Given this list of marker genes Htr3a, P2rx1, Glra4, P2rx2 (purinergic receptor P2X, ligand-gated ion channel, 2), Chrnb1, Gria2, Chrnb2, Chrm5 (cholinergic receptor, muscarinic 5), P2rx7, Grin2a, Chrnb3 (NCBI Gene Id 70535), Trpv1, P2rx4 (NCBI Gene Id 52272), Glra2, P2rx3, Slc17a7, Grik2, Htr3b, Chrna6, Glra3, Chrna2, Chrnb4, Chrna5, Glra1, Grik1, Chrna3, Chrna10, Grin2b, Chrna1, Chrng, P2rx5, Glrb, Chrne, Chrnd, P2rx6, Slc1a7, Chrna4, Chrna9, Chrna7, here is a description of the gene set: Mouse Gene Set: GOMF_EXCITATORY_EXTRACELLULAR_LIGAND_GATED_MONOATOMIC_ION_CHANNEL_ACTIVITY Enables the transmembrane transfer of an ion by a channel that opens when a specific extracellular ligand has been bound by the channel complex or one of its constituent parts, where channel opening contributes to an increase in membrane potential. studied in species Mus musculus